Given this list of marker genes ESR1, PIGY, RLBP1, MAPKAPK3, PDZD8, TUBB3, ANKRD11, OVOL2, SCAPER (NCBI Gene Id 92909), FBN1, KLHL7, PLXND1, FKRP, MT-ND3, PEX5, PRR12, PUM1, CEP250, KCNA1, PITX3, GLYCTK, POLD1, ANO10, FEZF1, ANKRD55, SEPSECS, ACTL6B, SLC18A3, LRP2, COX11, CDK19, MT-ND6, LRP4, BRCA2, PRPS1, MAGEL2, ALMS1, PHGDH, RPGR, SLC45A2, SMCHD1 (structural maintenance of chromosomes flexible hinge domain containing 1), TBC1D2B (NCBI Gene Id 91449), MIEF1 (NCBI Gene Id 54471), MIR140, TUB, CLEC3B, OFD1, P4HTM, HSD17B10, ERCC1, HRAS, NUS1, RAX2, SEMA3E, AGO2, PGAP1 (NCBI Gene Id 80055), MT-TC, WDR81, LMNB1, SIX3, GJA1, NDUFV2, PMS1, SLC38A8, ESAM, NOG, SMARCE1, TRAF3IP1, LRPAP1, BCOR, GRIK2 (glutamate ionotropic receptor kainate type subunit 2), PLEKHM1, MPL, KCNT1, DOCK7, PEX3, AP1B1, APC, CFHR3, NLRP3, SDHAF1, MT-ND5, CHKA, CTNNB1, STAG2, SLC35A2, DARS2, ADAMTSL4, RIMS1, PRKCZ, MFN2 (NCBI Gene Id 9927), GNA11, SPG11, CTNNA1, SLC39A14, TARS1, CKAP2L, POLR1D, TFG, TREX1, FLRT3, YAP1, NMNAT1, CORIN, IFNGR1, MTTP, SMARCA4, PCARE, KIF11, DNA2, POMT2, CLCC1, TOMM7, PARS2, SUMF1, CLN8, KRT14 (NCBI Gene Id 387571), NF1, HPS5, CD109, GTPBP3, MCAT, TUBA3D, EXOSC3, PTCH1, ATXN3, TRAPPC9, EMC1, SLC38A3, EXOSC2, CFHR1, LTBP2, SLC52A2, BRAF, GABRA5, PPP2CA, NDUFS8, SNRNP200, SV2A, TSEN2, BBS12, WDR45B, HKDC1, KIF1A, DCT, FRAS1 (NCBI Gene Id 84949), PCDH15, MAP2K1, ATF6, AIRE, FXN, KCNA2, OCA2, PDXK, ARHGDIA, PRDM5, ARX (aristaless related homeobox), BRCA1, TBC1D24, PMPCB, TMEM98, BUB1B, SF3B2, CDON, TRAK1, MT-ATP6, POLE, VWA8, TRIP13, WHRN, KIZ, PTPN22, PRPF3, SSBP1, PRUNE1 (prune exopolyphosphatase 1), TUBB4B, SMG9, PANK2, TGFBR2, CRB1, FOXP1, SOX3, CEP78, CHRND, MMP23B, CYP4V2, AKT3, CAPN5, WNT10A, POMT1, PRTN3, CEP19, ATP8A2, SCYL1 (SCY1 like pseudokinase 1), TNFSF11, ADAM9, MIR184, MYO9A, ITGB6 (integrin subunit beta 6), VPS13C, ARHGEF18, NDUFB10, VPS35, ATRX, TIMP3, RNU12, SLC25A19, WDR19, ACTB, OPN1LW, FH, MAPT, MECR, ATP6V1A, ARID1B, NFIX, BBIP1, COL9A2, COL13A1, NARS2, ERCC4, PGK1, TRAPPC11, TEFM, KRT5, MCOLN1, FRMD7, PAX6, PUF60, GLRX5, NAB2, DDR2, NEK2, AP3B2, CRIPTO, MT-TL1, DNAJC6, SOBP, ARMC9, FN1, AP4B1, ATP5F1E, HSD3B7, BBS5 (Bardet-Biedl syndrome 5), SALL2, TRNT1, NDUFAF2, COL7A1, ATN1, YME1L1, PANK4, ELOVL1, DNAJC13 (NCBI Gene Id 285196), AFF4, ATOH7, CDKL5, NUBPL, COL8A2, TGIF1, MAB21L1, ATP6V0A1, ABCD1, SLC7A14, SCN1A, SUOX, HLA-A, KCNQ2, ALPK1, SMO, HGD, TTLL5, PEX26, MTRFR, CRX, ZNF408 (zinc finger protein 408), TEK, OPN1MW, CTNND2, PMS2 (NCBI Gene Id 91271), SDHA, FOXG1, RHO, EDNRB, MTOR (mechanistic target of rapamycin kinase), ASB10, AAAS (aladin WD repeat nucleoporin), ABCA4, RIC1, CEP120, NYX, FGF14, AFG2A, EPRS1, POLH, C1QTNF5, BTNL2, CSPP1, CTLA4, ITM2B (integral membrane protein 2B), ST14, MSX2, NAA10, SDHB, GP1BB, FOXH1, HMBS, IKZF1, PNPLA6, NOD2, PSMD12, CNNM4, LRIT3, FGFR3, NDP, CLN5, RERE, ELP4, MT-TL2, PRDM16, GPR179, ANKH, ZNF469, PHYH, HCCS, ADARB1, JAK2, LUZP1, IGBP1, CHMP1A, TP53, EYS, PLA2G6, PEX12, NEU1, CRPPA, XRCC4, PDE6G, AIP, TTC8, FGFR2 (NCBI Gene Id 2263), CSF1R, SUFU, AFF3, SCLT1, NFKB2, CFAP410, CLN3, IDH3A, TUBGCP6, GRIN2D, DPM1, DNMT3B, BMP4, GRK1, IL12A-AS1, NSUN2, POLG, SELENOI, DUSP6, ASPA, EIF4H, POLR1A, SLC25A22, CAMK2A (NCBI Gene Id 815), PAK2, TCOF1, COL2A1, PIK3R2, ADA2, GABRG2, PCYT2, RFWD3, TTC19, ATM, COL17A1, PERCC1, MAPK8IP3, RILPL1, MACF1, WDPCP, HCN1, MKS1, TCF4, PDE4D, XYLT1, NDUFAF4, TMEM231, AHDC1, CERT1, SETBP1, PIGU, TP53RK, CDH23, FAM161A, MIR204, NDUFV1 (NADH:ubiquinone oxidoreductase core subunit V1), CYFIP2, FOXRED1, SCN8A, CRYBB1, PACS2, GUCA1B, TSEN34, TUBGCP2, OAT, YY1, PEPD, GABRB2, RDH11, APOE, CHRNE, CCDC28B, TXNL4A, SOST, CST6 (cystatin E/M), ERCC2, XYLT2, OCRL, HPS4, H3-3A (NCBI Gene Id 3020), THSD1, DYRK1A, CHEK2, VAMP2, LIG4, RAB3GAP2, FANCI, CEACAM16 (NCBI Gene Id 388551), GIPC3, ERCC3, MT-TN, PRPF4, CACNA1B, SLC12A3, ISCA2, SLC6A19, UCHL1, LIFR, HSPG2, RP9, IMPG1, THOC2, TREM2, SLC13A5, SRY, NDUFS1, HMCN1, TMEM67, ITGA2, B3GLCT, CACNA2D4, IDS (NCBI Gene Id 3423), PI4KA, PEX16, CHRDL1 (NCBI Gene Id 91851), ACBD6, VPS13B, MT-CO2, USH2A, HGSNAT, SNAP25, MT-ND1, CC2D2A, CACNA1F, LAMB2 (laminin subunit beta 2), BCL10, MT-TH, FCSK, CACNA1D, NLRP1, TCIRG1, GDF6, ST3GAL5, ELMO2, PCYT1A, LZTR1, ITGB3, AP3B1, CNTNAP1, MMP1, ATP1A2, MBTPS2, NDUFAF8, MLXIPL, TTPA, CRYGC, EIF4G1 (eukaryotic translation initiation factor 4 gamma 1), FTH1, AMACR, FOXC1 (forkhead box C1), SNRPN, SZT2, TMEM270, DEPDC5, HS6ST1, KERA, KCNJ13 (potassium inwardly rectifying channel subfamily J member 13), BMPR1A, ADAMTS17, PDE6B, GSN, BUB1, GDF3, TSPAN12, SCN9A, UBAP2L, HPDL, MSH2, SAMD9L, NHS, AP3D1, LIMK1, TELO2, ATP1A3, RD3, BBS4, PSEN1, ERCC5, MAD2L2 (NCBI Gene Id 10459), SUCLA2, ADGRV1, NDUFB3 (NADH:ubiquinone oxidoreductase subunit B3), USP8, MORC2, CA2, NTRK2, ARID2, ANOS1, GTF2I, MT-ATP8, AGRN (agrin), OSGEP, NECAP1, FLVCR1, DUX4L1, NDUFS4, ARL6, SRD5A3, TYMP, FANCL, ANTXR1, PIEZO2, CLEC7A, PINK1, MYO6, POLA1, MBD5, ARNT2, PARK7, TWIST2, SOX10, CLCN6, BLOC1S3, GUCY2D, DDX3X, PEX14, PLG, SYT2, ROM1, NR3C1, AGTPBP1, BBS1, ZFYVE26, NODAL, PEX1, PRPF6, PLK4, SNCA, IFT74, EXOSC9, MUTYH, BRIP1, WDR11, IFT43, ATP5F1A, UNC119, PRORP, NDUFS6, DNM1, CACNA1I, IL2RB, ARSG, TRIM32, IKBKG, DHX38, RAD51, PDE6C, MAG, LRAT, RPGRIP1L, GBA1, CASZ1, FAS, MERTK, CABP4, SLC1A3, GAS1, BUB3 (NCBI Gene Id 9184), KMT2B (lysine methyltransferase 2B), XPC, MYO5A, NDNF, CRYAA, GTF2H5, FLT1, RORA, TRAPPC2L, ASPH, DTNBP1 (dystrobrevin binding protein 1), RNF113A, SPTBN1, FDXR, PDHA1, GRIN1, USH1G, KCNV2, FDX2, TMEM216, NF2, MICOS13, RCBTB1, CHP1, DHDDS, PPP3CA, CHN1, SON, FOXC2, IMPG2, AHI1 (NCBI Gene Id 54806), PHOX2A, CLP1, COG5, AIMP1, ITGA2B, INPP5E, FSCN2, AHSG, GJB2, ADNP, VRK1, MT-TW, TIMM8A, MAFB, GIGYF2, TGFBI, APP, MT-ND4L, DBH, D2HGDH, GPR143, MLX, DCN, RP2, VPS37D, ERF, RDH12, CASK, SLC31A1, HPS6, PLCB1, PRDX1, LARGE1, YEATS2, CNTN2, ATXN7, GPAA1, KIDINS220, GTF2IRD1, KAT6A, DOK7, MITF, NSMCE2, TAT, SLC25A46, PAX2, EPCAM, P3H2, PROK2, B3GALNT2, EBP, SOX11, FBXL4 (NCBI Gene Id 26235), STIL, PDZD7, ERCC8, BEST1, CEP164, ZNHIT3, MT-TQ, PIGT, USP45, CEP290, FILIP1, SLC39A4, PRNP, PDPN, RAPSN, CHD6 (chromodomain helicase DNA binding protein 6), AGBL1, POLG2, DLL1 (delta like canonical Notch ligand 1), FZD5, MARCHF6, TP63, TBL2, DKK1 (dickkopf WNT signaling pathway inhibitor 1), FBN2, TET2, WASF1, FREM2 (NCBI Gene Id 341640), MVK, MSH6, CHM, DIAPH1, XPA, PROS1, AP1G1, MMP19, CTSD, SKI, SEMA3A, POMGNT1, ATP5MK, AIFM1, MYO7A, CLTC, ZPR1, BRAT1, TGFBR3, MAF, DDB2, ZFX, MED25 (NCBI Gene Id 81857), HPS1, PTPN2, STAT6, SPATA7, AARS1, DOLK, PITPNM3, BTD, WDR26, GLI2 (NCBI Gene Id 50806), FARS2, HARS1, PALB2, KIF3B, TERT, PSAP, CACNA1E, IQCB1, NDUFB9, AP4M1, GAN, SLC25A24, SLC6A6, KCTD7, GRM6, H1-4 (NCBI Gene Id 3008), COL4A1, RPS20, RNU4-2, PQBP1, PIGN, GTF2E2, PIGA, MPDZ, BUD23, GGCX, LAMA1, POLR1B, TLR4, TSEN15 (NCBI Gene Id 92120), AP4S1, PIGS, RGS9, PIGQ, TOP3A, CFH, KMT2D, NRL, SMC1A, TMEM53, DLD, SFXN4, RGS9BP, SETD1A, NCF1, C1QBP, SATB1, TUBGCP4, DHX37, PLA2G5, CHRNB1, TWNK, HSD17B4, FANCC, LRRK2, PUS3, VPS51, CHD7, GMPPA, SARDH, ZNF423, VHL, NDUFAF3, RAB11B, PORCN, TPP1, TENM3, SDHD, CAMSAP1, TULP1, CREBBP, FGF17, FGFR1, COG3, SLC12A5, CACNA1A, AP1S2, ELOVL4, DPAGT1 (NCBI Gene Id 1799), GORAB, HK1, NDN, XRCC2, H4C9, IFT27, BAZ1B, SLC25A1, IFT172, UROD, RPE65, TNF, CDC42BPB, SLC4A10, TRPM1, WWOX, NAPB, CIB2, CLCNKB, MAP2K2, FRG1, PEX6, CLCN4, PLCD1, NHLRC2 (NHL repeat containing 2), PSEN2, LRP5, CNGB1, IL17RA, PRSS56, FIG4, BOLA3, FA2H, SORL1, INVS, B3GAT3, NDUFB11, CCR1, TANGO2, NAGA, SATB2, PIGP, ERAP1, PAX3, NPHP3, PEX19, PIGB, COL9A3, LCA5, FANCA, ZEB1, BAP1, LZTFL1, OTX2, TTR, GMPPB, HPS3, MKKS, COL9A1, HDAC4, TRAPPC12, YWHAG (NCBI Gene Id 96443), RAC1, SHANK3, TK2, IFT88, CHST3, HLA-B, SALL4, GABRD, ESPN, MUSK, ATIC (5-aminoimidazole-4-carboxamide ribonucleotide formyltransferase/IMP cyclohydrolase), COL25A1 (collagen type XXV alpha 1 chain), CDK8, MFSD8, BIRC3, LAMP2, CTNS, MT-TF, FANCG, CELF2, CDH3, UBA5, TMEM240, LETM1 (NCBI Gene Id 3954), NPHP4 (nephrocystin 4), STX3, ADRA2B, DOHH, VAMP1, GABBR2, GNB1, B4GAT1, TNFRSF11A, NBAS, ALDH3A2, RALGAPA1, PRCD, TSFM, SYT1, FOXL2, NDUFA6, NDUFA11, P4HA2, PITX2, PODXL, THPO, PRPF31, KIAA0586, RBMX, ENG, TOMM40, RS1, MLH1, SPTBN4, UROS, IL10, GRM7 (NCBI Gene Id 2917), COL18A1, LCAT, DPYD, CACNA2D1, CDC42, EIF2B1, PRRT2, YARS1, SLC4A2, SLC5A7 (solute carrier family 5 member 7), NDUFS2, CNGA1, GRXCR2, ESRRB, OPA3 (NCBI Gene Id 8186), STIM1, BBS7, SLC19A2, PCDH12, FGF12, STOX1, REV3L, UFC1, CBS, CCND1, ADPRS, ROBO3, CALR, SPRY4, TMEM126B, PCNA, KCNN2, TSEN54, STX1A, FANCE, HEXB, METTL27, SOX4, EIF4A2 (eukaryotic translation initiation factor 4A2), CCDC141, PROM1, SH2B3, KRAS, C19orf12, MEN1, RMRP, GNAQ, WARS2, FGF8, ABCA1, TUBA1A, SAG, SCO2, MT-TK, IMPDH1, PEX7, OSTM1, TRAF3IP2, TAOK1, CRLS1, CERKL, IL17RD, COQ2, ARL3, SCN4A, ELN, HLA-DPA1, TIMMDC1, ALG11, NOP56, CDHR1, ASNS, MAK, SMARCB1, NPTX1, TBC1D20, RPGRIP1, UFM1, DPF2, LIM2, AGBL5, RBP3, SLC25A4, IL17RC, H4C3, COG4, EFEMP1, DCC, NDUFS7, UBE2T, FKBP6, DACT1, LYST, PEX11B, AMPD2, VPS11, NDE1, NCAPG2, IBA57, WFS1, MALT1, NR2E3, CLTRN, SLC2A1, WDR45, SLC24A1, LSS, TRAF7, TRIM44, PRIMPOL, ITPR1, IL17F, BBS2, HLA-DPB1, CFI, SLC4A11, KCND3, HLA-DRB1, TGFB1, FZD4, SLX4, CARS1, GLB1, EXOSC8, FLNA, CTC1, SYNGAP1, MPLKIP, IL23R, ABCC6, DUX4, SF3B1, NDUFA1, CA8, EDNRA, TRANK1, TACR3, UBAC2, MTHFS, CFAP418, CAMK2B, KRT12, PRKDC, DNAJC30, OPN1SW, SMARCC2, TMEM138, KRT3, BBS10, ANGPTL6, HECW2, FZR1, LRMDA, COPB2, PRPH2, GP1BA, TOPORS, KIF14, ADAMTS10, TRIO, CCDC47, SNX10, FANCD2, MTFMT, HEXA, POLR2A, CDH1, PYCR2, EEF1A2, IDH3B, BLOC1S5, MMACHC, APOA1, SH3BP2, TTI1, ZMIZ1, SAR1B, TMEM237, CHRNA1, COL3A1, TUBB4A, KIAA1549, SYNJ1, GM2A, GUCA1A, RNF13, NADK2, DTYMK, COX6B1, DRAM2, RRAS2, GNAT2, AFG2B, CNGB3, DLAT, MT-ND2, LYRM7, TBCK, EARS2, PPP2R1A, MFF, GATA2, MYOC, SCN3A, GNS, C4A (NCBI Gene Id 720), RAB3GAP1, TRRAP, AHR, OGT (O-linked N-acetylglucosamine (GlcNAc) transferase), AP4E1, KANSL1, TASP1, EPM2A, PIK3CA, EIF2B3, WAC, ENPP1, HIKESHI, TUBB2B, TBX1, PDGFB, KIF1C, MT-TV, KARS1, NOTCH3, HADHA, NR2F1, LAMC3, NPHP1, KLRC4, SREBF1, MT-CO3, GPR101, RFC2, CWC27, ALG3, FDFT1, CLRN1, RNU4ATAC, RDH5, RFT1, KCNAB2, CEP85L, HMX1, DNM1L, PEX10, SEMA4A, HESX1, COQ7, HTRA2, POLR1C, RRM2B, VSX1, DISP1, ARPC4, POU3F4, MGME1, SNAP29, USH1C, AFG3L2, DOCK6, USP48, PDSS2, PHF6 (PHD finger protein 6), PLCH1, ARL2, SMARCD1 (SWI/SNF related, matrix associated, actin dependent regulator of chromatin, subfamily d, member 1), REEP6, TINF2, CACNA1G, TYR, NEDD4L, SALL1, DALRD3, CHAT (NCBI Gene Id 1103), HLA-DQB1, CLCN2, CLN6, GNAS, GABRB1, SAMD7, SOX2, GNB3, RBP4, PRKN, ATP5F1D, NOTCH2NLC, RAB18, CEP57, GABRA2 (gamma-aminobutyric acid type A receptor subunit alpha2), FBXO28, NDUFAF5 (NCBI Gene Id 79133), SETD5, BBS9, SAMD12, POGZ, KIF21A, IFT140, PDE6H, GRIP1, POMK, RHOA, MT-CYB, ZIC2, IL2RA, RP1, MARK3, FBXW7, GNAT1, CLCN7, PEX13, RP1L1, CYSLTR2, GRHL2, EDN3, SDCCAG8, PPT1, SH3TC2, ACO2, GRN, FANCB, GTPBP2, GALC, SLC1A2, IL12B, AK9, CPSF3, GUSB, MT-CO1, COL11A1, NRAS, CEP41, ARID1A, FANCF, VCAN, NDUFS3, GTF2IRD2, ARL2BP, ARSA, SPEN, SHH, AKT1, IL12A, GJB6, CYP27A1, VLDLR, CYP1B1, SPTBN2, SCN2A, TACSTD2, ABCA7, PYCR1, PDE6A, CD247, ARSK, LRP1, YIF1B, MEFV, MT-ND4, COX7B, MFRP, MC1R (NCBI Gene Id 4157), UBE4B, BDNF, TMEM126A, KCNB1, TFE3, MT-TS2, NDUFAF1, TWIST1, ALG2, PIKFYVE, MAP3K7, POLR3GL, SERPINI1, KIF5A, NEUROD2, MED12, RTN4IP1, FKTN, PROKR2, MTRR, RGR, FOXE3, ATPAF2 (NCBI Gene Id 91647), TLCD3B, DNMBP, MICU1, ZEB2, CARS2, STAT4, GATA1 (GATA binding protein 1), PNPT1, ARHGEF2, LMBRD2 (LMBR1 domain containing 2), SLC24A5, AIPL1, RAB28, CA4, PXDN, COQ4, OPA1, LONP1, PRPF8, ZNF513, CHD3, VPS4A, CNGA3, CTNND1, PET100, PEX2, ERCC6, CHST6, PPP1R12A, FANCM, MTR, RAD51C, RIMS2, POC1B, CNKSR2, IQSEC1, WT1, DPP6, RNASEH1, TDO2, CLIP2 (CAP-Gly domain containing linker protein 2), PLOD1 (NCBI Gene Id 5351), KCNC2, here is a description of the gene set: Abnormality of vision species: Homo sapiens Human Gene Set: HP_ABNORMALITY_OF_VISION Abnormality of eyesight (visual perception).